The following is a description of a gene set: Neighborhood of CD97 CD97 molecule in the GNF2 expression compendium Human Gene Set: GNF2_CD97 studied in species Homo sapiens Neighborhood of CD97, and this is the list of marker genes: PTGER4, AOAH, RIN3, TUT7, STK10, APOBR, ITGB2, ITGAL, SELPLG, PTGER2, ADAM8, ADGRE5, GIMAP6, MYO1F, ID2, LITAF, HLA-F, OSTF1, JAK1, PTPRC, CD244, IQGAP1, ELF4, GPR65, HLA-G, BIN2, IL10RA, HLA-E, CYTIP, CX3CR1, DOK2, RAP1B, STK38, CD300A, ADCY7, PSTPIP1, CLEC2B, EFHD2